Given this list of marker genes Ncr1, Hcst, Myl6, Ccl4, Vim, Jun, Ctsd, Nkg7, Tspo, Ms4a4b, Calm2, Crip1, Selplg, Fcer1g, Tyrobp, Lgals1, Tm6sf1 (NCBI Gene Id 83487), Jund, Klrd1, Ankrd44, Fos, Ccr2, Cdc42, Ahnak, H2az1, Klf2, Emp3 (epithelial membrane protein 3), Anxa1, here is a description of the gene set: studied in species Mus musculus Genes negatively differentially expressed in cell type: NK cell upon treatment with cytokine: TNF-α in mouse lymph nodes in vivo. Cytokines mediate cell-cell communication in the immune system and represent important therapeutic targets. A myriad of studies have highlighted their central role in immune function, yet we lack a global view of the cellular responses of each immune cell type to each cytokine. To address this gap, the authors created the Immune Dictionary, a compendium of single-cell transcriptomic profiles of more than 17 immune cell types in response to each of 86 cytokines (>1,400 cytokine-cell type combinations) in mouse lymph nodes in vivo. A cytokine-centric view of the dictionary revealed that most cytokines induce highly cell-type-specific responses. For example, the inflammatory cytokine interleukin-1β induces distinct gene programmes in almost every cell type. A cell-type-centric view of the dictionary identified more than 66 cytokine-driven cellular polarization states across immune cell types, including previously uncharacterized states such as an interleukin-18-induced polyfunctional natural killer cell state. Mouse Gene Set: CUI_NK_CELL_TNFA_RESPONSE_DN from publication Cui A, Huang T, Li S, Ma A, Pérez JL, Sander C, Keskin DB, Wu CJ, Fraenkel E, Hacohen N (PMID 38057668)